The following is a description of a gene set: Genes from the green module which are up-regulated in HAEC cells (primary aortic endothelium) after exposure to the oxidized 1-palmitoyl-2-arachidonyl-sn-3-glycerophosphorylcholine (oxPAPC). species: Homo sapiens Human Gene Set: GARGALOVIC_RESPONSE_TO_OXIDIZED_PHOSPHOLIPIDS_GREEN_UP from publication Gargalovic PS, Imura M, Zhang B, Gharavi NM, Clark MJ, Pagnon J, Yang WP, He A, Truong A, Patel S, Nelson SF, Horvath S, Berliner JA, Kirchgessner TG, Lusis AJ (PMID 16912112) Oxidized phospholipids are thought to promote atherogenesis by stimulating endothelial cells (ECs) to produce inflammatory cytokines, such as IL-8. In studies with mouse models, we previously demonstrated that genetic variation in inflammatory responses of endothelial cells to oxidized lipids contributes importantly to atherosclerosis susceptibility. We now show that similar variations occur in cultured aortic ECs derived from multiple heart transplant donors. These variations were stably maintained between passages and, thus, reflect either genetic or epigenetic regulatory differences. Expression array analysis of aortic EC cultures derived from 12 individuals revealed that >genes were regulated by oxidized phospholipids. We have used the observed variations in the sampled population to construct a gene coexpression network comprised of 15 modules of highly connected genes. We show that several identified modules are significantly enriched in genes for known pathways and confirm a module enriched for unfolded protein response (UPR) genes using siRNA and the UPR inducer tunicamycin. On the basis of the constructed network, we predicted that a gene of unknown function (MGC4504) present in the UPR module is a target for UPR transcriptional activator ATF4. Our data also indicate that IL-8 is present in the UPR module and is regulated, in part, by the UPR. We validate these by using siRNA. In conclusion, we show that interindividual variability can be used to group genes into pathways and predict gene-gene regulatory relationships, thus identifying targets potentially involved in susceptibility to common diseases such as atherosclerosis., and this is the list of marker genes: IFNE, RCAN1, STIP1, MALT1, CHD2, LINC-PINT, LDLR, SOCS3, SLC4A7, CSNK1G1, CPEB4, CPNE8, DUSP6, SGMS2, IDI1, ANKRD28, ETV5, CREM, HDAC9, FAM120AOS, GNE, GEM, TNFRSF10A, AKR1B10, SIK1, RAB23, TMEM171